The following is a description of a gene set: species: Homo sapiens Human Gene Set: GOMF_FILAMIN_BINDING Binding to a filamin, any member of a family of high molecular mass cytoskeletal proteins that crosslink actin filaments to form networks and stress fibers. Filamins contain an amino-terminal alpha-actinin-like actin binding domain, which is followed by a rod-domain composed of 4 to 24 100-residue repetitive segments including a carboxy-terminal dimerization domain., and this is the list of marker genes: SMAD4, DPYSL4, RFLNA, CRMP1, MICALL2 (NCBI Gene Id 79778), FBLIM1, DPYSL3, TMEM67, HSPB7, RFLNB, NEBL, SYNPO2, CEACAM1 (NCBI Gene Id 634)